Given this list of marker genes Wnt5a, Ppard, Ctsl, Mreg, Ptgs2, Msx2, Fermt1 (NCBI Gene Id 241639), Ctnnb1, Gal, Psen1, Krtap21-1, Psen2, Barx2, Cdh3, Notch1, Myo5a, Trpv1, Gsdma3, Wnt10b, Tgfb2, Akt1, Dsg4, here is a description of the gene set: Mouse Gene Set: GOBP_HAIR_CYCLE_PHASE studied in species Mus musculus The cyclical periods of growth (anagen), regression (catagen), quiescence (telogen), and shedding (exogen) in the life of a hair; one of the collection or mass of filaments growing from the skin of an animal, and forming a covering for a part of the head or for any part or the whole of the body.